Given this list of marker genes IL1B, RIPK2, BMI1 (BMI1 proto-oncogene, polycomb ring finger), FOXP3, IL1A, SHH, here is a description of the gene set: studied in species Homo sapiens Any process that activates or increases the frequency, rate or extent of immature T cell proliferation. Human Gene Set: GOBP_POSITIVE_REGULATION_OF_IMMATURE_T_CELL_PROLIFERATION